The following is a description of a gene set: studied in species Mus musculus Mouse Gene Set: GOMF_RETINOIC_ACID_BINDING Binding to retinoic acid, 3,7-dimethyl-9-(2,6,-trimethyl-1-cyclohexen-1-yl)-2,4,6,8-nonatetraenoic acid., and this is the list of marker genes: Ugt1a8, Rara, Cyp26a1, Cyp26c1, Serpina5, Ugt1a7c, Cyp26b1, Crabp2, Nr2f2, Ugt1a10, Lcn12, Cyp2w1, Crabp1, Ugt1a1, Fabp5, Rxra, Igf2r, Ugt1a9, Lrat, Ugt1a2